Given this list of marker genes Bard1, Nbn, Mre11a, Brca1, Rad50, Rbbp8, here is a description of the gene set: species: Mus musculus Mouse Gene Set: GOCC_BRCA1_C_COMPLEX A protein complex that contains the BRCA1-BARD1 heterodimer, CtIP and Mre11/Rad50/NBS1 (M/R/N) complex, and binds to DNA at DNA damage sites. BRCA1-C binding ta damaged DNA is required for DNA damage-induced Chk1 phosphorylation and the G2/M transition checkpoint.